The following is a description of a gene set: species: Mus musculus This event has been computationally inferred from an event that has been demonstrated in another species.<p>The inference is based on the homology mapping from PANTHER. Briefly, reactions for which all involved PhysicalEntities (in input, output and catalyst) have a mapped orthologue/paralogue (for complexes at least 75% of components must have a mapping) are inferred to the other species. electronically inferred by orthology from the curated human pathway part of: Biosynthesis of specialized proresolving mediators (SPMs) Reactome Pathway: Biosynthesis of DPA-derived SPMs, and this is the list of marker genes: Alox12, Alox15, Ptgs2